Given this list of marker genes ENPP3, NUDT15, SAMHD1, ENTPD3, SMPDL3A, NUDT16, ENTPD7 (ectonucleoside triphosphate diphosphohydrolase 7), DCTPP1, DUT, ITPA, ADA (NCBI Gene Id 100), ENPP1, here is a description of the gene set: The chemical reactions and pathways resulting in the breakdown of a nucleoside triphosphate, a compound consisting of a nucleobase linked to a deoxyribose or ribose sugar esterified with triphosphate on the sugar. studied in species Homo sapiens Human Gene Set: GOBP_NUCLEOSIDE_TRIPHOSPHATE_CATABOLIC_PROCESS